Given this list of marker genes Sv2a, Mtdh (metadherin), Nexn, Ada, Lin7b, Dsc2, Lsr, Ptprk, Lyn, Rtn4, Atp1a1, Cdh13, Ctnnal1, Traf4, Tnk2 (tyrosine kinase, non-receptor, 2), Cldn6, Asb17 (NCBI Gene Id 66772), Ezr, Ocln, Fermt2 (NCBI Gene Id 218952), Dchs2, Kit, Shroom4, Sh3bp1 (NCBI Gene Id 20401), Dnmbp, Pacsin2, Kirrel1, Bmpr2, Cldn34b3, Flnb, Sigmar1, Slc8a1, Dlg3, Cttn, Parvb, Pvr, Yes1, Ctnnb1, Rpgrip1l, Mpp2, Wnk4, Pcdhb12, Ilk, Jcad, Rap1b, Arhgef5, Iqgap3, Cdh1, Itga6, Kcnj2 (NCBI Gene Id 16518), Syne2, Mip, Itga2, Zfyve21, Sdcbp, Cadm4, Itgb1, Flrt2, Cdc42, Cdca3, Sirt2, Ank2, Cdh6, Frmd6, Cldn34c5, Evpl, Frmd4b, Bin2, Ajm1, Afap1 (actin filament associated protein 1), Nectin3, Pnn, Sdccag8, Micall2, Cav2, Snta1, Coro2b, Fbp2, Add3, Itga5, Mdc1, B4galt1, Wdr1, Tbc1d2, Arhgap17, Vamp5, Lims2, Rangrf, Mtss1, Ldb3, Itgb5, Rapgef2, Sntb2, Clasp1, Wtip, Nfasc, Mylk, Atat1, Fyb1, Cd2, Micall1, Slc2a2, Rho, Jak2, Ppp1r9b, Nectin2 (NCBI Gene Id 19294), Ubox5, Parvg, Lcp2, Ptpn6, Trip6, Lpp, Fblim1, Specc1l, Pdlim2, Zfp185, Gfral, Abcb11, Frmpd2 (FERM and PDZ domain containing 2), Atp6v0a2, Flrt3, Mpp4, Dlc1, Ctnnd2, Aoc1, Capn2, Epha5, Lims1, Cdh9, Slc31a1, Ect2, Cadm1, Ankrd23 (NCBI Gene Id 98473), Tmem204, Slc2a1, Mapre1, Ahi1, Gja3, Cdh22, Shroom1, Prx, Flot1, Myh9, Ncam1, Fhod1, Cdh4, Ctnnd1, Dcaf6, Actr3, Synpo2, Pdxp, Cldn22, Sntb1, Atp1b1, Iqgap1, Wwp1, Pard6g, Grhl2, Tns4 (NCBI Gene Id 217169), Prkch, Lrrc7, Gja10, Pik3r1, Parva, Samt3, Actn1, Rufy3, Esam, Pard3 (par-3 family cell polarity regulator), Prkcz, Skap1 (src family associated phosphoprotein 1), Magi1, Atn1, Arhgap21, Add1, Cldn15, Tle2, Ildr2, Cldn34c3, Des, Pcdhgc3, Tjp3, Akt1, Cadm3, Lama3, Arpc2, Tesl1, Gsn, Pkp2, Wwtr1, Efnb2, Ppp1ca, Gja4, Prkd1, Samt1d, Slc8a3, Magi2, Slc5a1, Dixdc1, Cd2ap, Fchsd2, Pak1, Dsp, Sgsm3, Cdh19, Cav3, Flcn, Afdn, Cldn3, Efna5, Clmp, Tm4sf20, Cd53 (CD53 antigen), Cldn2, Tgfbr1, Irf2, Wnk3, Ccdc88c, Dag1, Aif1l, Dsg1b, Ildr1, Itgb6, Cdhr18, Smpx, Samt2, Ctnna1, Atp7b, Evl, Fat2, Nrap, Nectin4, Ptpra, Itga7 (NCBI Gene Id 16404), Mpp7, Nphs2, Adam10, Crb3, Gjb4, Cldn23, Nphp4 (nephronophthisis 4 (juvenile) homolog (human)), Ank3, Fermt3, Il1rl1 (NCBI Gene Id 17082), Zfp384, Rap2c, Rai14, Ahnak, Lin7c (NCBI Gene Id 99335), Mapk3, Cdc42bpa, Krit1, Tec, Prickle4, Crb1 (crumbs family member 1, photoreceptor morphogenesis associated), Ssx2ip, Flrt1, Mapk1, Col17a1, Jup, Pgm5, Cldn17, Dsc1, Xirp1, Itga11, Hepacam, Tjap1, Bcar1, Ccnd1, Gm14569, Scin, Ash1l, Heg1, Gria1, Nectin1, Shroom2, Itgb4, Afap1l1 (actin filament associated protein 1-like 1), Mapre2, Alkbh6, Ctnna2, Camk2d, Pikfyve, Pxn, Rnd1, Pdlim4, Atp2a2, Dsg2, Adcyap1r1, Actb, Bcar3, Cdc42bpb, Arl2, Tchp, Slc6a4, Avil, Prune1, Mpp3, Myadm, Pkn2, Mpp1, Rala (v-ral simian leukemia viral oncogene A (ras related)), Amot, Gjb2, Rhou, Apbb1ip, Clca2, Dlg4, Pard6b, Camsap3, Tes, Kifc3, Cib2, Rsu1, Flna, Itga1, Carmil2, Cdhr2, Rigi, Sorbs1, Sh3pxd2a, Actn3, Shc1, Sorbs2, Itga4, Cask, Gja8, Myh2, Map3k1, Trpc6, Lim2, Oprm1, Arvcf, Obscn, Mxra8, Prag1, Nherf4, Pdpk1 (3-phosphoinositide dependent protein kinase 1), Cd99l2, C1qtnf5, Cldn11, Peak1, F11r, Cdh7 (cadherin 7, type 2), Vav1, Svil, Layn, Kcna5, Ptk2, Fes, Stx3, Cldn34c4, Ndrg1, Clic4, Abcc2, Sapcd2, Limk1, Pkp1, Cdh3, Cyth2, Nos1ap, Luzp1, Bbln, Cldn14, P2rx7 (NCBI Gene Id 18439), Cldn1, Lmln, Cldn5 (claudin 5), Epcam, Was, Tnfsf13b, Adra1b, Tmem65, Stx2, Abcb1b, Gab1, Gje1, Wasf1, Ocel1 (occludin/ELL domain containing 1), Scn2a, Sorbs3, Fabp7, Sipa1l3, Prkca, Magi3, Gjb3, Jam2, Anxa6, Dsg1a, Amtn, Vapa, Cdh26, Epb41l3, Samt4, Gjb1, Flii, Msn, Usp33, Igsf21, Ctnna3, Erbin, Gjb5, Pdlim7, Jam3, Cpne3, Itk, Zyx (NCBI Gene Id 97340), Fscn1, Gjd2, Col13a1 (collagen, type XIII, alpha 1), Senp1, Cldn8, Lcp1, Jag1, Limd1, Fat1, Cbl (NCBI Gene Id 12402), Vinac1, Ssh2, Abi2, Panx1, Stard8, Arhgap24, Scn4b (sodium channel, type IV, beta), Ddx6, Cntnap2, Apc, Synpo, Cldn34c2, Lasp1, Lima1, Hnrnpk, Dbn1, Themis, Tgm1, Itgb8, Ptprj, Clasp2, Nphs1, Dnm2, Pdlim3, Cav1, Trpv4, Cfl1, Def6, Atp1a2, Cdh18, Tgfb1i1, Igsf11, Nme2, Xirp2, Dlg1 (discs large MAGUK scaffold protein 1), Kdf1, Pdzd2, Rap2b, Map2k1, Cldn34b1, Prkcg, Usp53, Alox8, Pals1, Hamp2, Phldb2, Fap, Pecam1, Pik3ca, Hck, Misp, Cdk4, Cldn25, Kcnj11, Src, Ptk2b, Lpxn, Arl14ep, Kcna1, Itgav, Cdh17, Tiam1, Arhgef7, Myo1e, Gjc3, Cldn4, Poldip2, Lck, Aqp3, Actn2, Cldn16, Notch1, Smad7, Prima1, Cdh8, Ehd4, Tjp1, Sh3gl1, Tek, Plec, Itgb2l, Cldn18, Gak, Cldn34c6, Ajuba, Srcin1, Scrib, Ybx3, Keap1, Tln2, Ppl, Pdpn, Pdcd6ip, Itgb1bp1, Itga3, Pard6a, Ptprm, Arhgef6, Gja5, Scn8a, Baiap2l2, Nrp1, Nck1, Vegfa, Gjd3, Ceacam2, Gjb6, Fgf13, Dock5, Dsg4, Amotl2, Abcb4, Itgbl1, Dnd1, Fgfr4, Hamp, Armc5, Coro1a, Cdh10, Sympk, Sptbn2, Eppk1, Plxdc1, Cxadr, Anxa5, Fndc1, Trpc4, Ptpn12, Amotl1, Scn5a, Ceacam1, Nedd9 (neural precursor cell expressed, developmentally down-regulated gene 9), Lmo7, Tada1, Hmcn1, Dsg3, Panx3 (NCBI Gene Id 71631), Dbnl, Erc1, Sh3pxd2b, Cldn34d (NCBI Gene Id 74987), Pcdh1 (protocadherin 1), Fer, Synm, Adgrb1, Epb41l5, Dctn4, Tln1, Hpn, Zap70, Grb2, Itgb7, Map2k2, Gjd4, Cldn9, Cldn12, Cldn34c1, Pik3r2, Snap23, Cd3e, Fermt1, Palld (palladin, cytoskeletal associated protein), Samt2b, Mast2, Slc4a1, Sdc4, Patj, App, Kcnd2, Cgnl1, Cdh12, Cass4, Adgrl3, Calb2, Ptprc, Rexo2, Fam107a, Itgb3, Ptk7, Pcdha9, Fzd5, Cldn20, Srp68, Ppp3ca, Aqp7, Bves, Epha2, Oxtr, Plekha7, Actg1, Cldn34b2, Slc9a1, Focad, Tnks1bp1, Cdh24, Frmd5, Lat, Tmigd1, Gjc1, Fxyd1, Cldn10, Kazn, Podxl, Uba1, Flot2, Tbcd, Tmem47, Pard3b, Ppfia1, Kirrel2, Enah, Prkci, Wasf2, Lama1, Itgb2, Epb41l4b, Ccn3, Pmp22, Myh1, Abcb1a, Pof1b, Crb2, Efs, Neurl2, Kirrel3, Rab13, Opalin, Ngfr, Cldn19, Git1, Gja6, Cdsn, Pcdhga12, Fbf1, Asap3, Klf11, Ubn1, Cdh2, Strn, Cldn13, Fmn1, Tns1, Adam15, Lin7a, Dmd, Ccdc85c, Gja1, Dlg5, Nphp1, Mapk15, Gm1123 (predicted gene 1123), Nf2, Myzap, Grb7, Plcg1, Kcna2, Pdlim1, Slc3a2, Yap1, Ambra1, Mlc1, Map4k4, Plekhg5, Arhgap31, Pkp4, Sgca, Itga2b, Kdr, Pkp3, Thsd1, Cldn34b4, Epha4, Cyth3, Havcr2, Cdh20, Tns3, Cldn24, Vcl, Vezt, Shroom3, Cxcr4, Itgal, Tns2, Tesl2, Vasp, Mpdz, Cdh11, Akr1b1, Prkcd, Ajap1, Samt1b, Tspan33, Marveld2, Pcdh9, Ptpru (protein tyrosine phosphatase receptor type U), Cntnap1, Scn1b, Capza1, Aqp4, Fzd4, Sh3kbp1, Csk, Pcdh12, Niban2, Klhl24, Bloc1s6, Jaml, Cdc42ep4, Scn1a, Vangl2, Mmp13, Dst, Slc9a5, Rasip1, Pdlim5, Gjc2, Dstyk, Pip5k1c, Tjp2, Arhgap26, Cgn, Pals2, Twf1, Ccdc85a, Cyth1, Pdzd11, Rhoa, Dsg1c, Dll1, Cdh15, Marveld3, Frmd4a, Pkd2, Rdx, Prkcz2, Nrxn1, Fgfrl1, Frs2, Vsig10l2, Cldn34a, Nox1 (NADPH oxidase 1), Igsf5, Skp1, Actn4, Ccdc85b, Il16, Sptbn4, Spata13, Arhgef2, Nox4, Tenm2, Pak2, Dpp4, Espn, Perp, Cyba (cytochrome b-245, alpha polypeptide), Ywhah, Dsc3, Krt8, Rap1a, Cldn7, Stard10, Sptan1, Akap6, Adam17, Cdh5, here is a description of the gene set: studied in species Mus musculus Mouse Gene Set: GOCC_ANCHORING_JUNCTION A cell junction that mechanically attaches a cell (and its cytoskeleton) to neighboring cells or to the extracellular matrix.